The following is a description of a gene set: Mouse Gene Set: ZFP882_TARGET_GENES from publication Yevshin I, Sharipov R, Kolmykov S, Kondrakhin Y, Kolpakov F (PMID 30445619) studied in species Mus musculus, and this is the list of marker genes: Kntc1, Gm15610, Bola2, Ptbp1, Wdr37, Slc9a8, Gpr68, Trpm1, Crot, Cacng3, Rex1bd, Gprin1, Mfsd2b, Fbll1, Khdc4, Ralgapb, Ywhag, Gm26247, Btbd19, Cacng2, Ube2i, Cyp4a28-ps, Arrdc3, Tram1, Rad51c (RAD51 paralog C), Gtf3c6, Smg7 (SMG7 nonsense mediated mRNA decay factor), Klf1, Magt1, Rfx2, Ralbp1, Hspa4, Smg5, Tbc1d10b, Olig3, Mcf2l, Srsf1, Mbtps2, Mroh1, Ncor2, Mir7b, Tsen54, Eif1ad, Gm9506, Arhgap26 (NCBI Gene Id 71302), Rora, Sgce, Marchf4, Adgrl3, Golga5, Cltc (NCBI Gene Id 97762), Mrpl21, Setd1a, Zbtb25, Capza1, Ubald1, Atf7ip, Mtif3, Cwc15, Kank3, Gm15039, Tcea2, Ipo13, Kcnt2, Glra1, Kdm4d, Sinhcaf, Zbtb1, Ino80dos, H2-M5, 5031434O11Rik, Lag3, Gm24296, Mapk8ip2, Barhl1, Vwc2l, Togaram2, Rfwd3, Scrt1, Ino80d, Lrrc23, Pcdhga8, Gm11292 (predicted gene 11292), Ninj2, Satb2, Cyb5r4, Exosc8, Gm26885, 1700023H06Rik, Ncoa4, Fmc1, Spry4, Gpr62, 2410002F23Rik, Ptp4a1, Usp1, Rsrc2, Caskin2, Tyw1, Dnmt3a, Hspa9, Doc2g, Tex14, Frat1, Gm22122, Omg